Given this list of marker genes WDR45, PPP3CB, MOAP1, TRIM32, RAB3GAP2, ELAPOR1, IRGM, LRSAM1, PIP4K2A, MCOLN1, SNX4, ANXA2, ATG2A, ULK1, PIP4K2B, SH3GLB1, PIP4K2C, SNX7, RAB3GAP1 (NCBI Gene Id 338380), WIPI1, GRN, SNX30, BECN1, RALB, SNX18, here is a description of the gene set: Any process that activates or increases the frequency, rate or extent of a process involved in the formation, arrangement of constituent parts, or disassembly of a vacuole. Human Gene Set: GOBP_POSITIVE_REGULATION_OF_VACUOLE_ORGANIZATION studied in species Homo sapiens